Given this list of marker genes Itgb2l, Lypd11, Pram1, Tyrobp, Abr, Lypd10, Cd177 (CD177 antigen), Bcr, Dnase1l3, Myd88, Dnase1, Myo1f, Stxbp3, Itgam, Ptafr, Scnn1b, Anxa3, Pikfyve, Fcer1g, Spi1, Stx11, Gkn2, Itgb2, Syk, here is a description of the gene set: Mouse Gene Set: GOBP_NEUTROPHIL_ACTIVATION_INVOLVED_IN_IMMUNE_RESPONSE studied in species Mus musculus The change in morphology and behavior of a neutrophil resulting from exposure to a cytokine, chemokine, cellular ligand, or soluble factor, leading to the initiation or perpetuation of an immune response.